The following is a description of a gene set: from publication Fulcher JA, Hashimi ST, Levroney EL, Pang M, Gurney KB, Baum LG, Lee B (PMID 16785517) Genes down-regulated in monocyte-derived dendritic cells: LGALS1 versus LPS. Human Gene Set: GSE4984_GALECTIN1_VS_LPS_STIM_DC_DN studied in species Homo sapiens Human monocyte derived dendritic cells matured via galectin-1 or LPS., and this is the list of marker genes: LPP, TFIP11, TTC9, VASH2, BLTP3B, HSD17B7, EEFSEC, C2, PPAN, LGMN, NELFE, TMEM204, PPA1, UBE2S, RPN2, ARAP2, FANCD2, PLK3, RBP7, DOCK5, NEMF, TSEN54, TDP1, SPP1, JAGN1, SLC7A14 (solute carrier family 7 member 14), GTF2F1, RTN3, SPRY1, KLF7 (KLF transcription factor 7), PSMC2, TRMT2A, PSMD2, LY86, LBX1, POGK, GAR1, LHFPL4 (LHFPL tetraspan subfamily member 4), KIRREL3, GGA2, TSC22D1, DMWD, TMEM117, CUL2, LYAR, LILRB3, NELFA, UMPS, FBL, RARS1 (NCBI Gene Id 84715), IBTK, PSMB6, OXNAD1, PRDM4, GTF2F2, NFU1, MT1A, FDFT1, PTBP1, AASDH, LARP4, APOL6, ICE1, NAPEPLD, FAM234A, ISG20L2, BID, SBK1, P4HB, SYCP2L (synaptonemal complex protein 2 like), TAFA3, DPEP1, HSPA4, AMMECR1, AKAP1, SELP, STON2, PITX2, GSDME, GGTA1, CDK4, GALE, SDHB, CRHR2, SPDEF, KCNAB2, IRAG2, TMEM201, CPNE5, HSP90AB1 (NCBI Gene Id 3326), MTHFD1, SEMA4D, TULP3 (NCBI Gene Id 7289), GEM, CYP2R1, CRYGS, FYN, LRRC8C, CIMIP7, CLCA4, LAMA1, RNF126, ATP11A, ST3GAL5, HECW2, HSF1, TALDO1, GADD45G, EVPL, GORASP2 (NCBI Gene Id 26003), LRRC8B, CEACAM1, CDK2AP1, HAND2, PTPRE, IPO5, FAM163B, DERA, PDXK, GMPS, CLGN, AKT2, ADAM17, SGIP1, EMP1, ATRNL1, UTP25, MARS1, GCNT1, BLOC1S4, MAPKAPK2, TIMM17A, CHN1, CSDC2, CYTIP, ARL8A, SART3, TOMM5, CARS1, SRP68, C7, TXNL1, CGNL1, CSE1L, AFG2A, ADRA2B, ABTB2, NAA50, DISP2, B3GALT2 (beta-1,3-galactosyltransferase 2), GIPR, KCNK5, IRS1, TEX15, TASP1, CCNO, TTC39B, ACKR2, NANS, NUP43, SLC20A1, ANKRD22, WDR36, MRRF, RRN3, MYOM2, KLK6, PTGES3, ZC3HAV1L